The following is a description of a gene set: Increased concentration of total (conjugated and unconjugated) bilirubin in the blood. Increased total bilirubin species: Homo sapiens Human Gene Set: HP_INCREASED_TOTAL_BILIRUBIN, and this is the list of marker genes: MYO5B, POLG2, PIEZO1, LIPT1, PRKCSH, SLC4A1, KCNN4, PRF1 (perforin 1), CPT2, SEC63, TMEM67, DCDC2, LRP5, PFKM